Given this list of marker genes CAV1, ITGB4, ADRA2C, NCALD, STK32B, LAT2, WASHC2C, PNMT, CIAO3, VLDLR, POU4F1, TRH, C15orf39, CACNA2D2, PSD3, IL5RA, NBL1, GRK5, VOPP1, LCP1, ADCY7, HSPG2, RUNX1T1, MYRF, FBLN5, ROBO1, KDM4B, BAIAP3, C11orf21, SLC25A1, THSD7A, here is a description of the gene set: species: Homo sapiens Top genes from cluster 13 of acute myeloid leukemia (AML) expression profile; 91% of the samples are FAB M2 subtype, all bear the t(8;21) translocation producing the AML1-ETO fusion; indicate good survival. from publication Valk PJ, Verhaak RG, Beijen MA, Erpelinck CA, Barjesteh van Waalwijk van Doorn-Khosrovani S, Boer JM, Beverloo HB, Moorhouse MJ, van der Spek PJ, Löwenberg B, Delwel R (PMID 15084694) BACKGROUND: In patients with acute myeloid leukemia (AML) a combination of methods must be used to classify the disease, make therapeutic decisions, and determine the prognosis. However, this combined approach provides correct therapeutic and prognostic information in only 50 percent of cases. METHODS: We determined the gene-expression profiles in samples of peripheral blood or bone marrow from 285 patients with AML using Affymetrix U133A GeneChips containing approximately 13,000 unique genes or expression-signature tags. Data analyses were carried out with Omniviz, significance analysis of microarrays, and prediction analysis of microarrays software. Statistical analyses were performed to determine the prognostic significance of cases of AML with specific molecular signatures. RESULTS: Unsupervised cluster analyses identified 16 groups of patients with AML on the basis of molecular signatures. We identified the genes that defined these clusters and determined the minimal numbers of genes needed to identify prognostically important clusters with a high degree of accuracy. The clustering was driven by the presence of chromosomal lesions (e.g., t(8;21), t(15;17), and inv(16)), particular genetic mutations (CEBPA), and abnormal oncogene expression (EVI1). We identified several novel clusters, some consisting of specimens with normal karyotypes. A unique cluster with a distinctive gene-expression signature included cases of AML with a poor treatment outcome. CONCLUSIONS: Gene-expression profiling allows a comprehensive classification of AML that includes previously identified genetically defined subgroups and a novel cluster with an adverse prognosis. Human Gene Set: VALK_AML_CLUSTER_13